Given this list of marker genes Becn1, Pla2g2a, Pmpca, Mrps21, Slc22a3 (solute carrier family 22 (organic cation transporter), member 3), Romo1, Atp5mj, Rcc1l, Ndufa2 (NCBI Gene Id 17991), Armc10, Acsl5 (NCBI Gene Id 71879), Sco1, Degs1, Atp5f1c, Cyp2u1, Them4, Serac1 (serine active site containing 1), Slc25a26, Mrs2, Suox, Agk, Slc25a19, Abcb10, Atp5mc2, Armc1, Rnf185, Atp5pd, Ndufaf6, Efhd1, Cox16, Cycs, Hsd3b8, Tomm22, Pam16 (NCBI Gene Id 66449), Qtrt1, Dusp18, Rab32, Mrpl15 (mitochondrial ribosomal protein L15), Cox6c2, Slc25a1, Bcl2l10, Slc25a31 (solute carrier family 25 (mitochondrial carrier; adenine nucleotide translocator), member 31), Afg3l2, Slc25a45, Stat3, Tufm, Rexo2, Pdss1, Sox10 (SRY (sex determining region Y)-box 10), Coa8, Ifi27l2a, Cpt1a, Coq4, Mrpl27, Sarm1, Sod1, Dap3, Ndufb4, Slc44a1, Chchd6, Mrpl10, Ppp1cc, Rars2, Mrps33, Letm1, Fahd1, Ndufs8, Kcnk9, Hspd1, Cyb5b, Atpaf1 (ATP synthase mitochondrial F1 complex assembly factor 1), Ndufs4, Park7, Znfx1, Tmem11, Slmap, Spire1, Mrps6, Mt3, Bad, Kmo (kynurenine 3-monooxygenase), Slc25a29, Nln, Slc25a48, Mrpl57, Ndufb7 (NCBI Gene Id 98326), 4930550C14Rik, Nme3, Dele1, Coa7, Plekhn1, Dmd, Pln, Ndufb5, Vrk2, Gsdma3, mt-Nd1, Mrps10, Mrpl17, Mrps31, Vat1, Ndufb1, Slc27a3, Mff, Mgarp, Dusp21, Atpaf2, Tmem14a, Cebpzos, Clpx, Hsd3b4, Uqcrh-ps1, Gcdh, Thop1, Ndufb11b, Ugt1a6a, Prnp, Ptrh2, Tspo, Uqcc3, Abcg2, Zdhhc8, Cox20, Abhd6, Atp5mf, Cox17, Ndufa5, Tk2, Bdnf, Pla2g4b, Slc25a25, Chchd2, Tmem135, Ndufaf4, Mrpl55, Flvcr1, Uqcr10, Sord, Slc25a30, Srgap2, Cyp1a1, Gpam, Mrpl39, Pgam5, mt-Nd4, Tmem126a, Slc29a3, Rdh13, Ppp2r2b, Gpd2, Hsd17b8, Cox4i1, Maoa, Traf3ip3, Cox10, Bnip1, Dnm1l, Synj2bp, Tmx2, Dnajc11, Mpv17, Ogt, Armcx2, Uqcrb, Alas1, mt-Nd4l, Mrps12, Dnajc19, Slc25a51, Fundc2, Mavs, Armc12 (NCBI Gene Id 67645), Vps13a, Pisd, Foxo3, Hsd17b10, Etfdh, Timm29, Coa4, Htra2, Cox4i2, Plcd1, Mrps23, Cox6a1, Gsdmd, Dhfr, Noa1, Hk1, Bak1, Ogdh, Sdhaf3, Muc20, Ppif, Clpb, Stx17, Chchd7, Hadha (NCBI Gene Id 97212), Trak1, Mtor, Mrpl37, Mrps27, Suclg1, Cyp27a1, Sirt4, Selenon, Yme1l1, Ptpn1, Ndufv3, Trap1, Slc25a23, Mrpl21, Ndufs5, Mrps18a, Fate1, Ucp3, Mrpl54 (NCBI Gene Id 66047), Nme1, Cox14, Bcl2a1d, Tomm5, Slc25a12, Tmem14c, Mgst1, Vdac1, Dmpk (dystrophia myotonica-protein kinase), Rnaset2b, Ndufs1, Bid, Calm1, Nelfb, Prelid2, Epha4, Uqcc4, Cmc4, Chchd10, Usp30, Arg1, Chchd1, Akt1, Crat, Guf1, Micos13, Sh3glb1, Stmp1, Mapk8ip1, Miga1, Smim26 (NCBI Gene Id 277433), Acsl1, Smim20, Cox6b2, Gimap3, Slc25a15, Maob, Prelid3a, Star, mt-Nd3, Cyp11b1, Mrpl58, Cox8a, Gja1 (NCBI Gene Id 14609), Abcb6, Mcl1, Rab7, Slc1a3, Mief2, Ndufb9, Uqcc5, Slc25a28, Plec, Mrpl11, Gfer, Timm23, Alpl, Marchf5, Sirt3, Ikbke, Atp5mg, Uqcr11, Fis1, Tomm20, Adap2, Atp5f1e, Chchd2-ps, Sdha, Anxa1 (annexin A1), Ndufa10, Smcp, Surf1, Cibar1, Fundc1, Mpv17l2, Mrpl40, Prkn (NCBI Gene Id 50873), Coq2, Mtarc1 (NCBI Gene Id 66112), Card19, Aifm3, Afg1l, Cidea, Canx, Hkdc1, Tst, Bcl2, Prodh, Fzd9, Slc22a4, Sting1, Mapkap1, Pdk4, Reep1, Ufl1, Acsl6, Dhrs1, Ndufa4, Mrps17, Mrps7, Nrgn, Micu2, Exd2, Opa1, Cnr1, Samm50, Grpel2, Polg, Prodh2, Mrpl2, Rab5if, Mtch1, Phb2, Agpat4, Snn, Ifi27, Tomm40l, Rab11fip5, Slc25a36, S2bpcox16, Aifm2, Trabd, Mrpl53, Parl, 1600014C10Rik, Rnaset2a, Slc25a14, Twnk (twinkle mtDNA helicase), Fgr, Bcl2a1a, Ndufb6, Micu3, Bloc1s1, Gabbr1, Mtln, mt-Cytb, Bok, Akap1, Hsd3b9, Acadvl, mt-Nd5, Mrps14, Gpx4, Qtrt2, Hsd3b3, Snca, Ghitm, Slc25a5, Slc25a10, Ndufs7, Sfxn3, Armcx1, Ndufa3, Herc2, Ociad2, Higd2a, Immp1l, Pebp1, Atp5pf, Cox7b, Trmt10b, Diablo, Pank2, Sphk2, Immt, Tug1, Myoc (myocilin), Mrps30, Acadm, Tmbim6, Cox19, Tomm34, Ndufa12, Bbc3, Coq3, Mrpl41 (mitochondrial ribosomal protein L41), mt-Co1, Sirt5, Otc, Ndufb2, Aldh18a1, Wasf1, Nlrx1, Ass1, Coa6, Glud1, Aqp8, Rsad2, Hsd3b2, mt-Co2, Pla2g4c, Bnip3l, Pcx, Sfxn4, Mrps18c, Cisd2, Ubiad1, Slc25a43, Foxred1, Cyp27b1, Ndufc1, Spg7, Coa3, Coq5, Mdh2, Lyrm7, Hax1, Ndufa9, Mrps2, Uqcc1, Tmem160, Ndufa8, Slc11a2, Slc25a39, Mief1, Timm17a, Mrpl24, Cox7b2, Arl2, Mtnap1, Timm8a1 (NCBI Gene Id 30058), Clu, Nipsnap1, Coq7, Exog, Slc30a2, Mrpl18, Tmem65, Cpt1b (carnitine palmitoyltransferase 1b, muscle), Abca12, Plscr3, Mrpl16, Mrpl49, Pink1, Stard13, Mrpl38, Slc25a37, Slc25a40, Slc25a22, Haao, Slc25a47, Atpsckmt, Cisd1, Antkmt, Atp5pb, Cnp (NCBI Gene Id 12799), Tomm70a, Bnip3, Ugt2b37, Tmem70, Mrps35, Acat1, Ubc, Slc25a41, Timm10, Tamm41, Cabs1, Fndc1, Ldhb, Mrps34, Ndufb4c, Nme2, Coq8a, Sqor, Atf2, Acaa2, Coq8b, Tomm40, Slc25a35, Tomm6, Slc8a3, Ndufc2, Kif28, Slc30a9, Tspo2, Mrps16, Mrpl20, Abcb8, Pmpcb, Chchd5, Pgrmc1, Ndufs2, Sfxn5, Rtn4ip1, Acacb (acetyl-Coenzyme A carboxylase beta), Acsl3, Gpat2, Mrpl34, Ngrn, Mrpl23, Mtx1, Cstad, Uqcrh, Coasy, Tmem177, Nat8f1, Bax, Slc25a34, Ciapin1, Coq10b, Mrps24, Gadd45gip1, Uqcc6, Ndufa11b, Oma1, Ugt2b5, Calm2, Pptc7, Acadl, Pet100 (NCBI Gene Id 554362), Fam162a, Ndufb4b, Mccc1, Abcd1, Oxa1l, Miga2, Dmac1, Aurkaip1, Snph, Atp5f1b, Cox5a, Letm2, Tomm7, Endog, Mtarc2, Abca8b, Lyn, Fdx1, Cfl1, Plaat3, Mtg2, Letmd1, Mtfr1l, Cdc25c (cell division cycle 25C), Vdac3, Mrpl43, Gatm, Nnt, Lrrk2, Vdac2, Slc25a16 (NCBI Gene Id 73132), Rhot1, Ndufb10, Fdxr, Sdhb, Cyc1, Slc25a20, Mtch2 (mitochondrial carrier 2), Tmem186, Uqcrq, Smim30, Mrps18b, Mrpl35, Immp2l, Dnajc30, Spata19, Mrpl52, Psen1, Bcl2a1b, Cyb5r3, Atcay, Cox6b1, Mpc1, Sod2, Slc25a33, Slc41a3, Ndufa7, Prelid1, Rhot2, Slc44a2, Mthfd2l, Lgals3 (NCBI Gene Id 16854), Pld6, Mgst3, Ndufaf3, Uqcrfs1, Atad1, Ckmt1, Mrpl30 (NCBI Gene Id 69516), Tmco1, Mrpl28, Bnip3l-ps, Slc9b2, Sfxn2, Pdss2, Apoo, Bltp2, Uqcrc1, Mpc2, Fkbp10, Bcl2l1, Mcur1, Ndufv2, Nme6, Mtfp1, Ucp2, Golph3, Ccdc90b, Timm17b, Fbxl4, Ndufv1, Pnpt1, Cox11, Mrpl22, Ckmt2, Mcub, Nbr1 (NCBI Gene Id 17966), Mrpl14, Spata18, Pnpla8, Mrpl32, Timm21, Cpox, Mrpl51, Cps1, Pde2a, Slc22a14, Tyms, Nos1, Ifi27l2b, Irgm1 (NCBI Gene Id 15944), Atg9a, Timm8a2, Hmgcl, Phb1, Timm9, Nrp1, Bik, Slc25a13 (NCBI Gene Id 50799), Cox7c, Timm50, mt-Nd6, Ppox, Ndufb3, mt-Co3, Nipsnap2, Hadh, Ucp1, Sfxn1, Mrps9, Atp5me, Fpgs, Mrpl50, Slc25a32, Timmdc1, Cpt2, Tomm20l, Mrpl47, Dnajc15, Gk, Slc8b1, Acsl4, Ndufa6, Tmx1 (NCBI Gene Id 72736), Mrpl33, Timm22, Mrpl45, Trim14 (tripartite motif-containing 14), Alas2, Cep89, Flvcr2, Uqcrc2, Mrps25, Afg3l1, Adck1, Mul1, Prelid3b, Grk2, Bcl2a1c, Mrpl44, Mrpl42, Cox7a1, Cyp2b10, Mfn1, Bri3bp, Chdh, Slc25a4, Higd1a, Gstk1 (NCBI Gene Id 99356), Cox7a2l, Calm3, Atp5mc3, Mrpl12, Mrpl9, Eral1, Mrpl1, Pi4kb, Cox18, Hsd3b6, Slc25a21, Tafazzin, Cox6a2, Bltp1, Atp5mc1, Slc25a18, Atp5f1d, Hk2, Ttc19, Slc25a42, Atp5po, Cox15, Mrps5, Capn10, Slc25a44, Moap1, Csde1, Rhbdd1, Gper1, Mrps28, Gdap1 (ganglioside-induced differentiation-associated-protein 1), mt-Nd2, Crls1, Rps6kb1, Spart, Slc25a27, Sco2, Cox5b, Ndufab1-ps, Gcat, Coq9, Ntrk3, Rmdn3, Ptpmt1, Prkca, Hadhb, Rnf144b, Cyp2e1, Maip1, Hsd3b5, Mtx2, Tmem242, Mix23, Dmac2l, Mrps26, Hmgcs2, Acad9, Bcl2l2, Aifm1, mt-Atp6, Sdhd, Mrpl19, Slc27a1, Dhodh, Ldhd, Chchd3, Ndufab1, Tmem223, Cox7a2, Cox8b (NCBI Gene Id 12869), Slc25a11, Slc39a9, Micu1, Lpin1, Slc25a24, Mrpl13, Apex2, Idh2, Ivd, Tmem256, Coq6, Vps13c, Micos10, Ppp1r15a, Mpst, Armcx6, Atxn3, Bcs1l, Eci1, Timm10b, Chchd4, Cox8c, Timm8b, Slc25a46, Armcx3, Atp5f1a, Atad3a, Ndufa1, Ccs, Mlxip, Ndufa13, Acad11, Abcd3, Mfn2, Map1lc3b, Mrpl4, Dars2, Ndufs6, Cyp11a1, Mtg1, Aldh3a2, Nat8l, Ak2, Bdh1, Cyp11b2, Apool, Stoml2, Ndufaf5, Rnf5, Atp5mk, Shmt2, Timm44, Mrpl3, Smdt1, Nme4, Cyct, Mrps15, Msto1, Arl2bp, Fkbp8, Neu4, Triap1, Mrpl36 (mitochondrial ribosomal protein L36), Sdhc, Slc25a3, Grpel1, Asl, Gk2, mt-Atp8, Mcu, Mrpl48 (NCBI Gene Id 78314), Mrps22, Misfa, Timm13, Bckdhb, Fundc2b, Ptcd3, Dao, Fam210b, Bcl2l13, Cox6c, Rps3 (ribosomal protein S3), Pemt, Ndufa11, Acads, Ggnbp1, Ndufb11, Slc25a38, Slc3a1, Hccs, Src, Hsd3b1, Fech, AU015836, Tigar, Pigbos1, Ambp, Ubb, Tmem126b, Mtx3, Uqcc2, Ndufs3, Ndufs6b, Mrps11, Ccdc51, Elk1, Gramd4, Ndufb8, Smpd5, Myo19, Got2, Mrpl46, Abcb7, here is a description of the gene set: Mouse Gene Set: GOCC_MITOCHONDRIAL_ENVELOPE The double lipid bilayer enclosing the mitochondrion and separating its contents from the cell cytoplasm; includes the intermembrane space. species: Mus musculus